The following is a description of a gene set: An immune response taking place in an organ or tissues such as the liver, brain, mucosa, or nervous system tissues. studied in species Mus musculus Mouse Gene Set: GOBP_ORGAN_OR_TISSUE_SPECIFIC_IMMUNE_RESPONSE, and this is the list of marker genes: H2bc12, Pigr, Defa39, Defa17, Defa40, Ffar2, Defb39, Rnase2b, Gp2, Fau, Defa2, Ifnlr1, Defa30, Defb1, Apoa4, Defa26, Defa21, Defb40, Defa37, Defa22, Rpl39, Defb11 (defensin beta 11), Defa29 (NCBI Gene Id 93795), Ifnl2, Ear2, Defb2 (NCBI Gene Id 13215), Xcl1, 6030468B19Rik (RIKEN cDNA 6030468B19 gene), Camp, Ltf, Defb9, Il6, Defa20, Otud7b, Defb37, Pla2g1b, Ear6, Defa28, Igha, Tnfsf13, Defb38, Defa5, Defa38, Rab17, Umod, Ear1, Defa25, Defa3, Trex1, Defa41, AY761185, BC037156, H2bc21, Rnase2a, Epg5, Il4, Cldn2 (claudin 2), Defb10, Nod2, Ear10, Defa31, Ffar3, Defa35, Defa24, Defa23, Cd160, Ear14, Defa34, Cfh, Bpifb1, Defa42, Gcnt3